The following is a description of a gene set: species: Homo sapiens Human Gene Set: GOBP_REGULATION_OF_TYROSINE_PHOSPHORYLATION_OF_STAT_PROTEIN Any process that modulates the frequency, rate or extent of the introduction of a phosphate group to a tyrosine residue of a STAT (Signal Transducer and Activator of Transcription) protein., and this is the list of marker genes: HES1 (NCBI Gene Id 3280), JAK2, PARP14, FLT3, CSF1R, IL31RA, IL20 (interleukin 20, NCBI Gene Id 50604), TNFRSF18, PARP9, IL21, CTF1, IL12A, ARL2BP, KIT, TNFSF18, IL18, PIBF1, ERBB4, PTPN2, FGFR3, CNOT7, CNTF, OSM, IFNL1, INPP5F, IFNG